The following is a description of a gene set: part of: Diseases associated with glycosylation precursor biosynthesis Sialuria (MIM:269921) is caused by a metabolic defect where the UDP?N?acetylglucosamine 2?epimerase, N?acetylmannosamine kinase (GNE) gene lacks feedback inhibition resulting in constitutive overproduction of free sialic acid (Neu5Ac). Sialuria is characterised by a large cytoplasmic accumulation and urinary excretion of Neu5Ac. Sialurias differ from sialidoses, in which there is storage and excretion of 'bound' Neu5Ac. Defects in GNE also cause Nonaka myopathy (NK; MIM:605820), an early adult-onset disorder characterised by muscle weakness and wasting of distal muscles, especially the anterior tibial muscles. Defects in GNE also cause inclusion body myopathy 2 (IBM2; MIM:600737), an autosomal recessive disorder with a similar phenotype to Nonaka myopathy (NK). IBM2 is an adult-onset, proximal and distal muscle weakness and wasting disorder. Muscle biospsy reveals from sufferers shows a rimmed vacuole myopathy and the degenerating muscle fibers contained abnormal amounts of beta-amyloid protein such as that found in neurodegenerative diorders. However, there is no neurological symptoms in these patients (Argov & Yarom 1984). Reactome Pathway: Defective GNE causes sialuria, NK and IBM2 species: Homo sapiens, and this is the list of marker genes: GNE (glucosamine (UDP-N-acetyl)-2-epimerase/N-acetylmannosamine kinase)